Given this list of marker genes GLI2, H3-3B, SMARCD1, GLI1, SMO (NCBI Gene Id 6608), PTCH1, RB1, ARID1A, GLI4, CDK6, DPF1 (NCBI Gene Id 8193), DPF3, EZH2, H3-3A, CDKN2A, SMARCA4, SMARCC1, SMARCD3, ARID1B, RBBP4 (NCBI Gene Id 91125), CDK4, ACTL6A, SMARCE1, ACTL6B, EED, SMARCB1, SUZ12, SMARCD2, GLI3, SMARCC2, DPF2, here is a description of the gene set: studied in species Homo sapiens Human Gene Set: WP_TUMOR_SUPPRESSOR_ACTIVITY_OF_SMARCB1 Tumor suppressor activity of SMARCB1